The following is a description of a gene set: from publication Chen Y, Wang X (PMID 31504780) Human Gene Set: MIR215_5P species: Homo sapiens Genes predicted to be targets of miRBase v22 microRNA hsa-miR-215-5p in miRDB v6.0 with MirTarget v4 prediction scores > 80 (high confidence targets)., and this is the list of marker genes: ZBTB34, DNAH5, LPAR4, PRKD3, SRSF6, STX7 (NCBI Gene Id 8417), NSF, ZEB2, CRYBG3, PABPC4, CAMSAP2, PCDH7 (NCBI Gene Id 90855), MTMR4, WNK1, PCDH9, CXCL2, DYRK3, BHLHE22, RAB2A, OSBPL10, RPAP2, EREG, ARFGEF1, MCPH1, UTP25, PDP1, SCN3A, ANAPC10, FRMD4B, ATF1, PREPL, NKAIN2, IFI44L, TMPO, WDR44, NIPAL1, FNDC3B, TMLHE